Given this list of marker genes Hbegf, Pawr, App, Reep3, Cavin1, Col1a2, Ptpn12, Tenm3, Pdlim7, Rab34, Ctxn1, Prss23, Arl4c, Bmp4, Npnt, Syt11, Gm33887, Rdh10, Prnp, Cmtm7, Gng3, Eloc, Rps6ka3, Ghr, Sox4, Nefl (NCBI Gene Id 18039, neurofilament, light polypeptide), Lpar4, Cyp1b1, Irs1, Plk2, Eid1, Cnn2, Abhd2, Pwwp3b, Tnfrsf12a, Tuba1a, Sdc1, Ncs1, Acsl4, Acta1, Cdkn2b, Kif5c, Kctd10, Ier3, Cd276, Rbp1, Rap2b, Wls, Cdk6, Phip, Rhob, Tmem123, Dsp, Vim, Cdkn1a, Rbms1, Pdlim5, Lratd2, Igfbp5, Rras2, Frmd4b, Cryab, Dusp14, Marcks, Col1a1, Sh3glb1, Skil, Metrnl, Epha1, Zfp266, Cxadr, Sema3c, Bmp1, Akt1, Coro1c, Stx6, Cav1, Msn, Lrp8, Scoc, Phldb2, Zfp52, Dusp6, Myadm (myeloid-associated differentiation marker), Tmem47, Tspan9, Sh3bgrl, Csnk1g1, Grb10 (growth factor receptor bound protein 10), Sox11, Tmbim1, Slc39a6, Gsn, Limd2, Nuak1, Bdnf, Prom1, Tgfb2, Mllt11, Pkp2, Pkia, Ppbp, Setd7, Itgav, Ro60, Gbp2, Farp1, Aif1l, Zyx, Lpp, Anxa2, Fam107b, Pou3f1, Col5a1, Acta2, Palld, Vgll3, Col4a5, B2m, Kpna4, ENSMUSG00000127189, Thbs1, Anxa3, Spsb1, Pmp22, Lhfpl6, Lrrfip1, Suz12, Zmynd8, Sh3pxd2a, Anxa5, Igfbp3, Elovl1, Gbp2b, Pitx2, Amotl2, Fzd2, Ccn4, Sertad4, Gng12, Rnd3, Prtg, Wnk1, Plin2, Idi1, Efemp1, Tnfrsf19, Jun, Gmfb, Actc1, Tpm1, Myc, Errfi1 (NCBI Gene Id 74155), Synpo2l, Adk, Tgfb1i1, Mmp14, Csn3 (casein kappa, NCBI Gene Id 12994), Pea15a, Glipr2, Ilk, Krt19, Tes, Trib1, Anxa1, Gnas, Marveld2, Yaf2, Flnc, Mtpn, Jag1, Gprc5a, Hacd1, Bmp2, Clic1, Igfbp4, Arap3, Lpgat1, Colec12, Hs6st2, S100a6, Ube2e1, Tmprss2, Socs6, Nt5e, T, Abracl, Perp, Rcn2, Tmcc3, Btg2, Crlf1, Krt18, Hmgn3, Fn1, Tpm4, Gng2, Nr6a1, Dusp1, Myh10, Rian, Axl, Ets1, Lgals1, Selenow, Id2, Ier5, Tubb6 (NCBI Gene Id 67951), Foxp1, Ammecr1l, Dock11, Ryk, Shb, Serpinb9, Ube2j1 (NCBI Gene Id 80530), Dbn1, Cnn1, Bhlhe40, Tagln, Soat1, Vcl, Dpysl2, Timp2, Vcan, Tax1bp3, Cgn, Stmn2, Dcbld2, Gli3, Bach2, Cd24a, Cpe, Fosl2, Tcf12, Klhl9, Actn1 (NCBI Gene Id 94278), Serpinh1, Crmp1, Slc25a24, Bnip2, Itga3, Efna5, Cd151, Poglut2, Col3a1, Myo1c, Klf6, Nrep, F3, Ppp1r18, Hmga2, Fndc3c1, Klf7, Ltb, Filip1l, Amfr, Malat1, Pxdn, Krt8, Loxl2, Pdgfb, S100a10, Wwtr1, Tceal8, Pdlim3, Ccn1, Gap43, Scd2, Car3, Sfn, Rhobtb3, Tmem43, Sulf1, Vat1 (NCBI Gene Id 26949), Plod2, Csrp1, Baz1a, Gm42047, Dyrk2, Itgb1, Meg3, Prickle1 (NCBI Gene Id 68784), Sprr2a1, Cmtm3, Ddx6, Pik3r3, Amotl1, Cald1, Phc2, Limd1 (NCBI Gene Id 52216), Cav2, Irs2, Klhdc2, Cited2, Cfl2, Parva, Sp5, Ccng1, Csf1, Col11a1, Abtb2, Wnt4, Steap2 (six transmembrane epithelial antigen of prostate 2), Steap1, Ttyh3, Capn2, Cdh2, Cldn12, Tspan2, Tpm2, Flna, Smo, Phlda1, Tmem30a, Rtn3, Cyfip2, Prpf40a, Samd4, Sema3e, Zdhhc9, Ahnak, Flrt3 (fibronectin leucine rich transmembrane protein 3), Cap1, here is a description of the gene set: Genes down-regulated in ES (embryonic stem cells) with defficient SUZ12. species: Mus musculus Polycomb group (PcG) proteins form multiprotein complexes, called Polycomb repressive complexes (PRCs). PRC2 contains the PcG proteins EZH2, SUZ12, and EED and represses transcription through methylation of lysine (K) 27 of histone H3 (H3). Suz12 is essential for PRC2 activity and its inactivation results in early lethality of mouse embryos. Here, we demonstrate that Suz12(-/-) mouse embryonic stem (ES) cells can be established and expanded in tissue culture. The Suz12(-/-) ES cells are characterized by global loss of H3K27 trimethylation (H3K27me3) and higher expression levels of differentiation-specific genes. Moreover, Suz12(-/-) ES cells are impaired in proper differentiation, resulting in a lack of repression of ES cell markers as well as activation of differentiation-specific genes. Finally, we demonstrate that the PcGs are actively recruited to several genes during ES cell differentiation, which despite an increase in H3K27me3 levels is not always sufficient to prevent transcriptional activation. In summary, we demonstrate that Suz12 is required for the establishment of specific expression programs required for ES cell differentiation. Furthermore, we provide evidence that PcGs have different mechanisms to regulate transcription during cellular differentiation. Mouse Gene Set: PASINI_SUZ12_TARGETS_DN from publication Pasini D, Bracken AP, Hansen JB, Capillo M, Helin K (PMID 17339329)